The following is a description of a gene set: Mouse Gene Set: GOMF_GDP_DISSOCIATION_INHIBITOR_ACTIVITY Prevents the dissociation of GDP from a GTPase, thereby preventing GTP from binding. species: Mus musculus, and this is the list of marker genes: Sh3bp4, Chml, Gpsm1, Gdi2, Ngb, Itgb1bp1 (integrin beta 1 binding protein 1), Ccdc88a, Rgs14, Arhgdib, Gpsm2, Arhgdig, Arhgdia, Sesn2, Gdi1, Eif5, Chm